The following is a description of a gene set: studied in species Mus musculus Human breast cancer has been characterized by extensive transcriptional heterogeneity, with dominant patterns reflected in the intrinsic subtypes. Mouse models of breast cancer also have heterogeneous transcriptomes and we noted that specific histological subtypes were associated with particular subsets. We hypothesized that unique sets of genes define each tumor histological type across mouse models of breast cancer. Using mouse models that contained both gene expression data and expert pathologist classification of tumor histology on a sample by sample basis, we predicted and validated gene expression signatures for Papillary, EMT, Microacinar and other histological subtypes. These signatures predict known histological events across murine breast cancer models and identify counterparts of mouse mammary tumor types in subtypes of human breast cancer. Importantly, the EMT, Adenomyoepithelial, and Solid signatures were predictive of clinical events in human breast cancer. In addition, a pan-cancer comparison revealed that the histological signatures were active in a variety of human cancers such as lung, oral, and esophageal squamous tumors. Finally, the differentiation status and transcriptional activity implicit within these signatures was identified. These data reveal that within tumor histology groups are unique gene expression profiles of differentiation and pathway activity that stretch well beyond the transgenic initiating events and that have clear applicability to human cancers. As a result, our work provides a predictive resource and insights into possible mechanisms that govern tumor heterogeneity. Human Gene Set: HOLLERN_PAPILLARY_BREAST_TUMOR from publication Hollern DP, Swiatnicki MR, Andrechek ER (PMID 29346386) Genes that have high expression in paplillary mammary tumors., and this is the list of marker genes: PLCE1, HPGD, HP, CEL, PGAP4, BBOX1, ARMCX4, KRT19 (keratin 19), ARMCX2, UGT8, ALDH1A3, SLC43A3, CSN1S1, RHOV (ras homolog family member V), CNMD (NCBI Gene Id 373170), HEY2, NRARP, WNT5B, MUC15 (mucin 15, cell surface associated)